The following is a description of a gene set: Mouse Gene Set: GOBP_NOREPINEPHRINE_METABOLIC_PROCESS studied in species Mus musculus The chemical reactions and pathways involving norepinephrine, a hormone secreted by the adrenal medulla, and a neurotransmitter in the sympathetic peripheral nervous system and in some tracts in the central nervous system. It is also the demethylated biosynthetic precursor of epinephrine., and this is the list of marker genes: Insm1, Atp7a, Kl, Akr1b1, Slitrk1, Gata3, Moxd1, Epas1, Hand2, Comt, Th, Dbh, Rnf180, Moxd2, Ly6e, Spr, Ednra, Prkn, Rnls, Pnmt (phenylethanolamine-N-methyltransferase), Rtl4 (retrotransposon Gag like 4)